Given this list of marker genes HAL, SLC1A7, FFAR3, NMS, URAD, ABCA15P, PRPH2, SOHLH2, SLC12A3, SSTR5, SYCP2, APLNR, ERVFRD-1, MC4R, MYOG, here is a description of the gene set: from publication Kinney SR, Moser MT, Pascual M, Greally JM, Foster BA, Karpf AR (PMID 20584988) Hypomethylated genes in prostate tissue from mice carrying hypomorphic alleles of DNMT1. Human Gene Set: KINNEY_DNMT1_METHYLATION_TARGETS Previous studies have shown that tumor progression in the transgenic adenocarcinoma of mouse prostate (TRAMP) model is characterized by global DNA hypomethylation initiated during early-stage disease and locus-specific DNA hypermethylation occurring predominantly in late-stage disease. Here, we utilized Dnmt1 hypomorphic alleles to examine the role of Dnmt1 in normal prostate development and in prostate cancer in TRAMP. Prostate tissue morphology and differentiation status was normal in Dnmt1 hypomorphic mice, despite global DNA hypomethylation. TRAMP; Dnmt1 hypomorphic mice also displayed global DNA hypomethylation, but were characterized by altered tumor phenotype. Specifically, TRAMP; Dnmt1 hypomorphic mice exhibited slightly increased tumor incidence and significantly increased pathological progression at early ages and, conversely, displayed slightly decreased tumor incidence and significantly decreased pathological progression at advanced ages. Remarkably, hypomorphic Dnmt1 expression abrogated local and distant site macrometastases. Thus, Dnmt1 has tumor suppressor activity in early-stage prostate cancer, and oncogenic activity in late stage prostate cancer and metastasis. Consistent with the biological phenotype, epigenomic studies revealed that TRAMP; Dnmt1 hypomorphic mice show dramatically reduced CpG island and promoter DNA hypermethylation in late-stage primary tumors compared to control mice. Taken together, the data reveal a crucial role for Dnmt1 in prostate cancer and suggest that Dnmt1-targeted interventions may have utility specifically for advanced and/or metastatic prostate cancer. studied in species Mus musculus